The following is a description of a gene set: Human Gene Set: GOBP_ENDOCRINE_PROCESS studied in species Homo sapiens The process that involves the secretion of or response to endocrine hormones. An endocrine hormone is a hormone released into the circulatory system., and this is the list of marker genes: TBX3, NPVF, GJA1 (gap junction protein alpha 1), PTPN11, CRY2, NOX1, TACR1, PRCP, CRHBP, HCAR2, INHA, EDN1, TSPO, CMA1, CGA, SELENOM, NKX3-1, F2R, HSD11B2, TAC1, ATP6AP2, RHOA, AVPR1A, PREP, GDF9, COMT, RASL10B, FGFR1, NDST2, GATA3, SUCNR1, PPARG, RPS6KA2, KDM5B, ACE, ACE2, RAB11FIP3, OXTR, C1QTNF3, MRGPRD, CRHR1, CTSZ, TRPV6, FZD4, GHRL, CYP19A1, AGTR1, ANPEP, CTSG, EDN2, KCNK9, NIBAN2, REN, CPA3, RAB11FIP1, GALR1, CORIN, INHBA, AGT, AGTR2, SPP1, EDNRB, APLN, RAB11FIP5, DRD5, OPRK1, POMC, CYP11B2, SMAD4, LEP, PCSK5, DAB2, GNRHR (gonadotropin releasing hormone receptor), SERPINF2, ENPEP, MME, TACR2, F2RL1, AQP1, RETN, INHBB, UCN, CRH, NOS3, MAS1, ECRG4, OR51E2, EDN3, CYBA, RAB8B, TMF1, ECE1, AVPR1B, WNK4, C1QTNF1, CRY1, GAL, KCNQ1, IL1B, GJA5, BMP6, FOXD1, FOXL2 (NCBI Gene Id 668), AVPR2